Given this list of marker genes Ghsr (NCBI Gene Id 208188), Ptger4, Scn11a, Kcnma1, Htr1d, Kit, Tacr2, Ghrl, Ptger3, Htr2b, here is a description of the gene set: species: Mus musculus Mouse Gene Set: GOBP_INTESTINE_SMOOTH_MUSCLE_CONTRACTION A process in which force is generated within smooth muscle tissue, resulting in a change in muscle geometry. This process occurs in the intestine. Force generation involves a chemo-mechanical energy conversion step that is carried out by the actin/myosin complex activity, which generates force through ATP hydrolysis. The intestine is the section of the alimentary canal from the stomach to the anal canal. It includes the large intestine and small intestine.